Given this list of marker genes Tbk1, Ubb, Uba52, Trim32, Ubc, Dtx4, Uba52rt, Trim21 (NCBI Gene Id 20821), Nlrp4c, Ddx41, Rps27a (ribosomal protein S27A), Irf3, Sting1, Trim56, here is a description of the gene set: studied in species Mus musculus Regulation of innate immune responses to cytosolic DNA Mouse Gene Set: REACTOME_REGULATION_OF_INNATE_IMMUNE_RESPONSES_TO_CYTOSOLIC_DNA